Given this list of marker genes H3-5, HDAC1, MBD2, NAP1L4, H1-9P, RNF169, SSRP1, EZH2, SMARCA1, SMARCC2, MACROH2A1, MBD3, HIRA (histone cell cycle regulator), SIRT6, PARP1, RNF168, ACTL6A, H1-1, H1-4, HMGN1, HMGN2, L3MBTL1, CHD4, MLLT10, ACTR6, H1-3, H3-3B, SUPT6H, H3-3A, HDAC2 (NCBI Gene Id 3066), HP1BP3, CGAS, SMARCA4, RNF4, H1-10, MLLT6, H1-6, MTA2, VRK1, ZNHIT1, RCC1, RBBP4, GLYR1, CABIN1, H1-2, ARID1B, DNTTIP1, HMGN4, NOC2L, HNRNPC, H1-8, SMARCD2, ARID1A, ACTB, H1-5, SMARCB1, PWWP3A, H1-7, HMGN3, H1-0, HMGA2, SMARCC1, SUPT16H, EZH1, CHD1L, SMARCA5, GATAD2B, HMGN5, SMARCE1, SAP30L, H3Y1, PARP2, H2AZ1, EED, here is a description of the gene set: studied in species Homo sapiens Human Gene Set: GOMF_NUCLEOSOME_BINDING Binding to a nucleosome, a complex comprised of DNA wound around a multisubunit core and associated proteins, which forms the primary packing unit of DNA into higher order structures.